The following is a description of a gene set: Mouse Gene Set: GOBP_TUBE_DEVELOPMENT studied in species Mus musculus The process whose specific outcome is the progression of a tube over time, from its initial formation to a mature structure. Epithelial and endothelial tubes transport gases, liquids and cells from one site to another and form the basic structure of many organs and tissues including lung and trachea, kidney, the mammary gland, the vascular system and the gastrointestinal and urinary-genital tracts., and this is the list of marker genes: Dab2ip, Pak4, Sostdc1, Ift52, Ext1, Gata6, Tbc1d32, Wnt3a, Nr2e1, Thra, Vash2, Rec8, Sphk1, Sox8 (NCBI Gene Id 20681), E2f2, Spink2 (serine peptidase inhibitor, Kazal type 2), Hmgcs2, Pdgfc, Agtr1b, Zfp157, Enpp1, Kdm2a, Tbx2, Naglu, Irx1, Ctsd, Nup50 (nucleoporin 50), Get1, Igfbp5, Rxra, Notch4, Umod, Hrg, Mir23a, Plk2, Adrm1, Ephb1, Hes1, Zfpm2 (zinc finger protein, multitype 2), Emp2, Hspb6, Ptk7, Egln1, Selenon (NCBI Gene Id 74777), Smad6, Hdac7, Ccdc39, Arhgap35, Angptl3, Tgfbr1, Atp7a, Plxnb2, Or10j5, Ephb4, Itgax, Spred1, Foxd1, Smpd3, Actg1, Cma1, Mcam, Ttbk2, Hoxa13, Sim1, Ascl1, Alox12, Wars2, Lrp5, Atrx, Pnpla6, Tgfbr3, Cfc1, Kras, Chd7, Smad5, Ace (angiotensin I converting enzyme), Src, Bmp5, Akr1b1, Stim1, Vash1, Hs2st1, Pknox1, St14, Mosmo, Deaf1, Casp8, Arg2, Hand2, Crispld2 (cysteine-rich secretory protein LCCL domain containing 2), Wnt5a, Cx3cl1, Hey1, Jun, Ang, Gh, Il12b, Rb1, Nphp3, Robo1, Uts2, Rc3h2, Ctsl, Rspo2, Clic4, Lama5, Hspa12b, Wdr83, Ubb, Meis1, Dspp, Nos3, Hpse, Hif1a, Prcp, Pik3r2, Foxm1, Mir302c, Hoxa7, Setd2, Optc, Bmpr1a, Ryr2, Hes3, Dlg5, Nr4a3, Fkbp8, Dnaaf3 (dynein, axonemal assembly factor 3), Ccl12, Shox2 (SHOX homeobox 2), Brd2, Nrxn3, Rspo3, Hoxb13, Pten (phosphatase and tensin homolog), Notch2, Sgpl1, Hmga1, Bcl10, Apob, Ppp3r1, Sema3e, Adamts12, Sec1, Zeb1, Mir143, Six1, Gpc3, Odad3, Asb2, Otulin, Efemp2, Ubp1, Esrp2, Cx3cr1, Stat3, Rubie, Itgb3, Wnk4, Slc23a1 (NCBI Gene Id 28202), Amotl2, Slc7a11, Flvcr2, Cckbr, Nrp1, Wars1, Gna13, Plxna4, Efnb2, Podxl, Foxe1, Rbpj, Apaf1, Cdh5, Notch1, Pak1, Mir92-1, Htatip2, Gbx2, Phb2, Atxn1l, Tyms, Ccr2, Ppp1r16b, Ctnnbip1, Tigar, Fgfr3, S100a1, Glul, Hmgb1, Mnx1, Spdef, Uts2r, Wnt2b (NCBI Gene Id 22414), Gmnc, Spata2, Adam15, Prdm1, Atxn1, Smarca1, Pank2, Fzd6, Naxe, Prok1, Rbpms2, Epha2, Il12a, Sall4, Rbbp9, Ago2, Cplane2, Vangl2, Zfp354c, Tead2, Hnf1b, Cyp1b1, Cdx2, Dysf, Nkx3-1, Mrtfb, Ncl, Ephb2, Flna, Inka1, Casr, Ccn3 (NCBI Gene Id 18133), Rock1, Lhcgr, Dzip1l, Foxj2, Ift57, Grhl3, Mir216b, Cps1, Wdr48, Invs, Ehd4, Tie1, Rnh1, Map3k3, Fzd5, Adipor2, Hoxb3, Rasip1, Lipa, T, Ccl24 (C-C motif chemokine ligand 24), Tfap2b, En1, Rhob, Sema4c, Hyal1, Ago1, Tjp1, Cib1, Edn1, Kdr (kinase insert domain protein receptor), Vegfd, Adgrg1, Marcks, Prkcb, Sox18, Pcnt, Plg, Irx3, Greb1l, Arl13b, Sftpd, Reg1, Hspg2, Stra6, Mir302a, Foxn1, Sox9 (SRY (sex determining region Y)-box 9), Epb41l5, Tcf7, Gdf6, Epha1, Fap, Acvr1, Filip1l, Adam12, Nkiras2, Scg2, Epn1, Apold1, S1pr1, Srf, Rab3a, Cxcr2, Kdm2b, Cxcl10, Sema3c, Rad21l, Smad3, Calcrl, Mef2c, Cxcl17, Yipf6, Tnn, Pofut1, Ptgs2, Nkx2-5, Atp2b4 (ATPase, Ca++ transporting, plasma membrane 4), Epha7, Psen2, Adm2, Tnfrsf1a, Rbp4, Angpt2, Gja1, Mir23b, Foxb1, Elk1, Dll1, Ep300, Pdpn, Zic5, Abl1, Fmn1, Xdh, Eif4g1, Anxa2, Nfatc3, Synj2bp, Hmox1, Hgf, Ferd3l, Etv5, Col4a3, Cthrc1, Dag1, Stx2, C3ar1, Cemip2, Itgb1bp1, Loxl3, Enpep, Chrd, Akp3, Gli1, Sec24b, Foxl1, Mir17 (NCBI Gene Id 723905), Pdcd10, Becn1, Pax2, Hdac9, Lgr4, Apela, Serpinf1, Atoh8, Scaper, Ttc8, Vasp, Nfe2l2, Coq7, Cic, Ptn, Vps52 (NCBI Gene Id 677216), Ncoa3, Fbxw7, Apoe, Bmi1, Plod3, Cd47, Amotl1, Tgfa, Lrp2 (NCBI Gene Id 99378), Hoxa11, Dvl2, Cby1 (chibby family member 1, beta catenin antagonist), Myh9, Sim2, Nog, Angptl6, Ang5, Rapgef3, Creb3l1, Runx1, F3, Gpld1, Pgk1, Nr3c1, Rarres2, Sfrp5, Ing2, Serpine2, Sdc1, Mir18, Sall2, Cat, Cfh, Ghsr, Npr2, Lzts2, Ecm1, Hesx1, Creb1, Mesp1, Sparc, Efna1, Adgrb2, Megf8 (multiple EGF-like-domains 8), Nras, Cbfa2t2, Vstm4, Cav1, Dsg2, Ift140, Pecam1, Tspan12, Wwtr1, Tcf7l2 (NCBI Gene Id 21416), Brpf1, Mir145a, Shank3, Bcl2, Sox4, Mir27b, Esm1, Mmp12, Fgfr2, Nodal, Kdm5b, Slc12a2, Hpgd, Cited2, Ada, Arhgap24, Gata5, Slit2, Lrp6, Ptprb, Eif2ak3, Tnfrsf12a, Dhcr7, Gjc1, Trp73, Sox10, Fzd3, Tead1, Wwp1, Myb, Tgfbr2, Ppp1r15a, Emc10, Hs3st3a1, Edn2, Nrxn1, Adam7, Sfta3-ps, Thrb, Hlx, Ilk, Smoc2, Rgma, Cdh13 (NCBI Gene Id 74373), Jmjd1c, Plcd1, Gas1, Vav3, Cebpa, Tbx4, Gsdmc2, Esrp1 (NCBI Gene Id 70076), Ddr1, Ahr, Ccn6, Crlf1, Adamts16, Fgfbp1, Dppa2, Eda, Smarca4, Aimp2, Heg1, Cd34, Mir216a, Loxl2, Cd36, Mir203 (microRNA 203), Mir19b-1, Wnt9b, Nus1, Pdgfrb, Prkd1, Med1 (NCBI Gene Id 19014), Id1, Tmem94, Chd8, Wnt1, Trim71, Prickle1, Mib1, Eng, Ramp1, Ghrl, Abcc2, Meis3, Agtr2, Rnf220, Mixl1 (Mix paired-like homeobox), Thbs4, Sdccag8, Cdkn1a, Nkx2-6, Akt1, Tnni3, Rnf213, Mir19a, Pax7, Hipk2, Plxna2, Odad4, Cspg4, Mir126b, Tcap, Kdm6a, Aqp2, Fgf6, Tnfaip2, Pdgfra, Clec14a, Adm, Nf1, Mme, Tnmd, Rhoj, Cux1, Prkacb, Wdr19, Rin2, Syk, Adrb2, Krit1, Meox2, Kat5, Tbx3, Kat2a, Sfrp2, Adamts2, Egfl7, Intu, Asxl1, Smad7, Pgf, Igf1, Timeless, Il17f, Npr3, Psg22, Fkbpl, Hgs, Slc1a1, Pxn, Gpr161, Csf1, Cxcr3, Tulp3, Cd44, Agtr1a, Prrx2, Bbs4, Srebf1, Fgf2, Foxc1, Cecr2, Rara, Hspb1, Flt1, Prrx1, Fgf7, Bmp2, Lepr, Heyl, Ctnnb1 (NCBI Gene Id 12387), Folr1, Stk3, Ccdc134, Gsta3, Pthlh, Fzd8, Itga5, Bax, Gata2, Mthfr (NCBI Gene Id 17769), Rpgrip1l, Klhl3, Prl2c2, Six2, Jak1, Sav1, Prkd2, Myocd, Gata3, Gzf1, Crkl, Pkd1, Kcnq1, Cd93, Amot, Acvrl1, Col4a2, Bak1, Nfia, Thbs1, Pspn, Rtl1, Tbx18, Inhbb (NCBI Gene Id 16324), Crhr2, Adgrf4, Nr2f2, Hhex, Brca1, Traf6, Ephb3, Nckap1, Asah1, Hif3a, Pcsk5, Wnt6, Rras, Edar, Fbn1, Slc31a1, Traf3ip1, Vcan, Zic2, Dact2, Slc8a1, Map2k1, Shroom3, Mthfd1l, Ski, Mir24-2, Tbc1d20, Klf5, Mmrn1, Cripto, Ninj1, Ovol2, Junb, Tmed2, Mapk8ip3, Sars1, Grem1, Lama1, Atp6ap2, Ndnf, Ecscr, Ift172, Pik3c2a, Pbx1, Pkd2, Rarg, Pdcd6, Rela, Ctsh, Sema4a, Fn1, Aggf1, Lhx1, Ift88, Ap3b1, Cd59a, Smo, Naa15, Itga3, Cysltr1, Prkca, Sox2, Cxcr4, Irx2, Spp1, Tfap2a, Mir20a, Bloc1s6, Epn2 (epsin 2), Ctns, Cdx1, Tmem201, Smad4, Ddah1, Egfl8, Lrp1, Shc1, Errfi1, Kctd10, Gdf11, Tlr9, Srpk2, Isl1, Paxip1, Col8a2, Cobl, Mfge8, Sp100, Ptk6, Mia3, Nkx2-1, Ccbe1, Tgm2, Ccn1, Tctn1, Fasl, Hoxd11 (NCBI Gene Id 319663, homeobox D11), Fmnl3, Elk3, Fgf18, Ass1, Nup133, Thbs2, Map2k2, Mir7-2, Cd40, Mdk, Ccdc103, Rgcc, Fzd4, Cd24a, Slc22a1, Lgals3, Emcn, C3, Gpx1, Rcbtb2, Npnt, Nfatc1, Ift25, Cc2d2a, Ntrk1, Wnt2, Lias, Myo1e, Vdr, Fendrr (Foxf1 adjacent non-coding developmental regulatory RNA), Itga2b, Traf4, Vav2, Fuz, Ambra1, E2f7, Stil, Pik3cd, Angpt1 (angiopoietin 1), Parva, Ywhaz, Pkhd1, Cdh2, Scnn1b, Hoxb7, Gata4, Ret, Ptprj, Sfrp1, Col2a1, Micall1, Ptgis, Mir30a, Nkiras1, Crh, Wnt7a, Ntn1, Ang2, H2-M3, Rps7, Sp1, Dlc1, Trp63, Foxc2, Klf4, Pacsin2, Vps4b, Ldlr, Itgb1, Pdpk1, Twist1, Hmga2, Rpl13a, Nkx2-2, Hsd11b1, Slc22a6, Ccn2, Unc5b, Pkdcc, Foxn4, Mecom, Hps1 (NCBI Gene Id 54334), Srpx2, Zc3h12a, Ncor2, Sall1, Etv4 (ets variant 4), Sirt1, Fosl2, Zmiz1, Mtss1, Bmp4, Cybb (cytochrome b-245, beta polypeptide), Vhl, Wnt4, Rnase10, Sp3, Gpr4, Tmem215 (NCBI Gene Id 320500), Man1a2, Calb1, Minar2, Mthfd1, Muc19, Adra2b, Gsc, Il1b, Hectd1, Nfib, Apln, Atp5f1b, Tafa5, Nppc, Comp, Pax6, B4galt1, Pfn1, Osr1, Adamts9, Tmem59l, Srsf6, Ccl5, Mapk14, Arhgap22, Foxf2, Add1, Tnrc6c, Alx1, Cd160, Ift122, Enah, Minar1, Anxa1, Tspan18, Robo2, Il10, Itgav, Bmp7, Tlr3, Cdc42, Smad2, Cav3, Sufu, Clcn2, Dchs1, Dll4, Shb, Tnf, Vegfa, Sash1, Alx4, Gjb5, Lox, Prom1, Pitx2, Cldn18, Nkx3-2, Hoxa1, Pax8, Meg3, Mks1, Ngp, Cdk20, Maged1, Stard13, Pik3ca, Gab1, Rab23, Adamtsl2, Map3k7, Grhl2, Klf2, Myc, Celsr1, Pdcl3, Ugt1a1, Sgcd, Ceacam1, Has2 (NCBI Gene Id 210441), Nox1, Gm28729, Il1a, Ereg, Rala, Spry1, Luzp1, Ednra, Mcidas, Cdx4, Mir24-1, Jmjd8, Mmp9 (NCBI Gene Id 99431), Spint1, Abca3, Grn, Adamts1, Adgrb1, Yjefn3, Tacstd2, Psen1, Egf, Cep290, Sos1, Cimap3, Wasf2, Yap1 (yes-associated protein 1), Ets1, Vezf1, Sulf1, Cyp1a1, Jam3, Nfatc4, Thy1, Gja5, Spry2, Pik3cb, Phactr4, Tmtc3, Itgb6, Rxfp1, Kit, Lgr5, Hrh2 (NCBI Gene Id 15466), Hs6st1, Col3a1, Kif26b, Wnt11, Nkx2-3, Bcas3, Ccno, Asb4, Gorab, Nrcam, Sox17, Epor, Rdh10, C1galt1, Plxnd1, Cyp1a2, Tmem107, Card10, Met, Cftr, Camp, Dcn, Tshz3, Flt4, Nprl3, Col4a1, Mtdh, Rbm15, Tgif1, Tmigd1, Stab1, Mapk7 (NCBI Gene Id 23939, mitogen-activated protein kinase 7), Lcn2, Gpr15, Col18a1, Rhoa, Fndc3b, Ptpn6, Epha4, Noto, Rap1a, Sema6a, Robo4, Bcam, Six4, Abca12, Eya1, Lep, Il6st, Bcl2l11, Qki (NCBI Gene Id 66145), Notch3, Lhx2, Cited1, Tbx5, Zfp950, Mmp2, Rnf207, Jcad, Setdb2, Clmp, BC028528, Ednrb, Fkbp10, Fyn, Pgr, Ece1, Dlg1, Foxp2, Ccm2, Rtn4, Tbxa2r, Erap1, Bsg, Tbx20, Gtf2i, Specc1l, Wt1, Hopx, Gak, Man2a1, Gatad2a, Angpt4, Phgdh, Fgf8, Tek (TEK receptor tyrosine kinase), Dact1, Prox1, Plcg1, Hey2, Eva1a, Tbx1, Mapk1, Kif3a, Mir302d, Lhx3, Rarb, Nipbl, Anxa3, Opa1, Cnmd, Lef1, Pbrm1, Stk4, Stox1, Cldn5, Map2k5, Zeb2, Mycn, Gadd45a, Fgf3, Hoxd13, Fat4, Pdgfa, Btrc, Fut1, Gdf7 (NCBI Gene Id 238057), Tal1, Pdgfb, Abcc8, Aqp11, Col8a1, Agt, Cysltr2, Clic3, Fer, Scrib, Adgrf5, Ang4, Mgp, Wnk1, Arid2, Ihh, Hk2, Perp (PERP, TP53 apoptosis effector), Ndp, Arid1a, Acat1, Ackr3, Vegfc, Commd5, Il18, Alox5, Foxp4, Itga7, Pde3b, Aimp1, Ptges3, Ramp2, Mir7-1, E2f8, Rasa1, Hs3st3b1, Cluap1, Epcam, Tnc, Pik3r3, Foxf1 (forkhead box F1), Spint2, Tsc1, Cfl1, Bag6, Lbx1, Jag1, Phex, Mical2, Mir217, Mylk, Anpep, Sema5a, Itpk1, Cul7 (cullin 7), Nrp2, Prok2, Emilin2, Ctsz, Tab1, Acvr2b, Vegfb, Ptch1, Ccl11 (NCBI Gene Id 20292), Fgf10, Zfp36l1, Hes5, Atf2 (NCBI Gene Id 97033, activating transcription factor 2), Stk40, Smad9, Gdf2, Fgfr4, Col6a1, Esr1 (NCBI Gene Id 13982), Hand1, Cela1, Jup, Spi1, Pik3r6, Nr4a1, Hbegf, Fgfr1, Prkx, Adgra2, Foxh1, Ntrk2, Dnaaf1, Tcf4, Hc, Jmjd6, Hdac5, Angptl4 (NCBI Gene Id 57875), Agr2, Wnt7b, Shh, Serpine1, Dvl1, Tert, Stat1, Ccr3, Itgb2, Thsd7a, Pkm, Foxa1, Prkaca, Csnk2b, Plcd3, Ar, Igf2, Casp3, Sh2b3, Lmo4, Pax3, Rora, S2bpcox16, Xbp1, Nkx2-9, Epas1, C2cd3, Ngfr, Lrg1, Gjb1, Mir302b, Gli3, Foxj1 (forkhead box J1), Pik3cg, Tgfb2, Egfr, Gdnf, Tgfb3, Chi3l1, Aplnr, Ccdc40, Tns3, Tgfb1, Itgb2l (integrin beta 2-like), Kat6a, Dicer1, Msx2, Mmrn2, Cdh1, Adgrb3, Otc, Fgf1, Mir27a, Sirt6, Etv2, Mst1, Smad1, Tmem38b, Csmd1, Cer1, Rock2, Ptk2, Pml, Nrarp, Bmper, Lemd3, Plau (plasminogen activator, urokinase), Sdc4 (NCBI Gene Id 99320), Sox11 (SRY (sex determining region Y)-box 11), Pparg, Id2, Percc1, Ptger4, Areg, Pf4, Mecp2, Ptprm, Oxtr, Aldh1a2, Akt3, Lta4h, Serpinf2, Gli2, Adtrp, Pou3f3, Wdpcp, Hhip, Tmem100, Epo, Fbln5, Mmp14, Mir329, Med12, Emx2, Pxdn, Egr3, Nedd4, Hoxa3, Ang6, Tfap2c, Mydgf, Prl7d1, Hoxa5, Ctnnd1, Myo18b, Aqp1, Brip1, Tgfbi, Foxa2, Emilin1, Ltbp3, Rapgef2, Abl2, C5ar1, Kif20b, Ssbp3, Rcn3, Gjb2, Tnfsf12, Glmn, Tsc2, Bmpr2, Cxcl12, Slc39a12, Ccl2, Dppa4, Ptk2b, Nkx6-3, Zic3 (zinc finger protein of the cerebellum 3), Ppp1ca (NCBI Gene Id 19045), Fgf9, Itgb8, Foxo4, Mapk3, Efna3, Mir367, Apoh, Pdx1, Epgn, Tcf21, Ism1, Adam8, Reck, Kif18a, Btg1, Tmem67, Hikeshi, Bdnf, Mmp19, Ipmk, Foxp1, Phf14, Tiparp, Lif